The following is a description of a gene set: species: Homo sapiens Oxidoreductases. Human Gene Set: MODULE_93, and this is the list of marker genes: CYP4B1, MDH1 (NCBI Gene Id 4190), COX7A1, UGDH, ETFB, FASN, PRDX4, UQCRFS1, HSD11B1, COX7A2, CYP1A1, NDUFS2, AKR1C3, NCF1C, DECR1, SDHC, SDHD, NDUFAB1, IDH1, COX5B, NDUFV1, ERP29, BCKDHA, SPR, DHRS3, ALDH1L1, PDIA4, ACOX1, GC, ALDH3A2, ALDH7A1, AKR1B1, EHHADH, HMOX2, PBLD, PRDX6, MTHFD1, ALDH1A1, NDUFA1, IDH2, ALOX5, HADHB, PAM, NQO1 (NCBI Gene Id 4834), MSMO1, GSTZ1, PRDX1 (NCBI Gene Id 5052), ACADL, CYP1B1 (NCBI Gene Id 1545), ACADSB, ALDH6A1 (NCBI Gene Id 4329), CH25H, AKR1A1, HSD17B7, HSD17B6, UQCR11, CYP2B6, UQCRB, CYP26A1, AKR7A3, P4HB, ALDH4A1, CDO1, ADH7, HNMT (NCBI Gene Id 3176), BCKDHB, ALDH5A1, NQO2, QSOX1, UQCRC2, MAOA, HSD17B10, NDUFB7, CYP2J2, NDUFS6, DHCR24, DHRS2, ALDH9A1, CYC1, FMO5, CYP3A4, NDUFV2, TXNDC12, GPX3, NDUFA4, ACADVL, TBXAS1, NDUFS8, PLOD3, ADH1C, ALOX15, BLVRB, ADH1A, MPO, CYP27A1, HADHA, CP, NDUFS3, MGST3, GPX2, CYCS (NCBI Gene Id 54205), ETFA, PTGIS, FADS2, QDPR, LDHA, SRD5A2, CYP2C19, FMO3, SC5D, CRYZ, AKR7A2, HAAO, AKR1C1, BBOX1, HPGD, MAOB, AOC1, COX6A1, NDUFB8, CAT, CYP3A5, COX7B, PAH, CYP4A11, NDUFB3, IDH3B, SORD, AOC3, CYP11B2, NDUFS4, CYP3A7, GLRX, CYBA, ADH4, PDIA3 (protein disulfide isomerase family A member 3), ALB (NCBI Gene Id 29004), PYCR1, COMT, FMO4, AKR1C2, AOX1, TDO2, NDUFA2, DAO, ALDH1A3, NCF2, CBR1, GSTO1, HSD17B4, UQCRC1, TXN2, CYP2C8, ALDH3A1, TTR, CYB5R3, COX6C, GLUD1, NDUFB1, HPD, SIVA1, TP53I3, IVD, COX7C, GPX4, ACADM, ALDH3B1, PLOD1, ABLIM1, ALOX15B, IMPDH2, XDH, MB, DPYD, GPX1, FADS1, DIO1, COX6B1, PHYH (phytanoyl-CoA 2-hydroxylase), SOD1, SELENOW, ACOX2